The following is a description of a gene set: Formation of the beta-catenin:TCF transactivating complex Human Gene Set: REACTOME_FORMATION_OF_THE_BETA_CATENIN_TCF_TRANSACTIVATING_COMPLEX species: Homo sapiens, and this is the list of marker genes: H4C3, H2AC6, LEO1, H3-3B, H2BC21, CDC73, H2BC1, H2BC3, CTNNB1, H4C4, TCF7L2, H3C1, H2AB1, H3C6, H4C13, H3C15, HDAC1, RUVBL1, H2BC5, BCL9, TRRAP, H2AC4, H2BC4, ASH2L, KMT2D, H2BC9, TERT, H2BC26, KAT5, PYGO1, LEF1, H2AX, H2BC12L, TLE3, H3C3, H2AC20, BCL9L, H2AC7, H4C15, CREBBP, H2BC6, TCF7L1, AXIN2, H4C12, H2BC11, H4C8, H3C10, H3C14 (NCBI Gene Id 8967), H3C11, H2BC12, H3C8, PYGO2, SMARCA4, TLE4 (TLE family member 4, transcriptional corepressor), H2AZ2, H2BC8, TCF7 (NCBI Gene Id 6932), MYC, H2BC7, TLE2, H2AC18, TCF4, H3C7, H4C6, H2BC13, H2BC15, H2AJ, H4C1, H2BC14, H3C13 (H3 clustered histone 13), H4C14, H3C2, H3C12, H2AC19, H3-3A, RUNX3, H4C2, H4C5, TLE1, H4C11, H4C16, H3-4, MEN1, H4C9, H2BC17, H3C4, H2BC10, EP300, H2AC8, RBBP5, H2AC14